The following is a description of a gene set: Human Gene Set: GOBP_SKELETAL_MUSCLE_SATELLITE_CELL_ACTIVATION The change of a skeletal muscle satellite cell from a mitotically quiescent to a mitotically active state following exposure to some activating factor such as a cellular or soluble ligand. In adult muscle, satellite cells become activated to divide and differentiate in response to muscle damage. species: Homo sapiens, and this is the list of marker genes: WNT7A, KLF5, EPHB1, SOX15, GJD4, CAPN3, MEGF10, KPNA1, XIRP1